The following is a description of a gene set: studied in species Mus musculus Negative feedback regulation of MAPK pathway Mouse Gene Set: REACTOME_NEGATIVE_FEEDBACK_REGULATION_OF_MAPK_PATHWAY, and this is the list of marker genes: Mapk1, Raf1, Braf, Map2k2, Mapk3, Map2k1